Given this list of marker genes PRP4K, PHOX2B, MKX, SRF, FN1, CMC4, SULT4A1, DNAJC24, TBC1D4, SLC10A7, MYOCD, LINC02694, RAB33B, CADM2, C15orf40, GFRA1, ITGA1, NIPBL, BBX, LSM6, TRAM1L1, SLC6A15, TGFBR1, MVB12B, ZNF426, CD300E, MAPK1IP1L, PTPN2, ARL17A, NXPH1, RSPO3, LVRN, TMEM59, MRC1, PLEKHG7, SOX14, RGL1, GPR135, ARID1A, FZD10, TMEFF2, GNG12, SLC39A8, BRD8, STEAP2, NALF1, PIK3R3, A1CF, CAPRIN1, SUCNR1, PIK3CA, ATP8B3, USP2, PCDH10, ZNF706, TRAPPC3, ALCAM, LPP, MYCBP, PURA, UBE2H, IL17RE, PHLPP1, NAP1L1, PLXDC1, AGO1, SPTLC2, ARID4A, UFSP2, STAT1, BID, ACOT13, MKNK2, PAK2, SOX12, PRAMEF13, ME2, KLB, FOXJ3, MBNL1, TRRAP, PIK3C2G, METAP2, KHDRBS2, METTL8, SP100, GLCCI1, KCNK9, PRAMEF14, SAA2, PCDHB9, POGZ, ZNF660, CD36, SOX9 (SRY-box transcription factor 9), ABRACL, PDE12, BBS2, EIF2AK2, MTRFR, SLC22A17, C1QTNF7, CA3, GNL3, NLK (NCBI Gene Id 51701), ELP4, RAPGEF2, ZNF24, FGF12, SLC25A26, ITGBL1, MXI1, SDK1, BACH2, SH2D1A, CCDC178, BICD2, MAP3K2, BTG1, C1orf146, HEATR5A, ABCG8, MRPS5, COCH, POGK, CCDC125, ZNF268 (zinc finger protein 268), PSMA1, AMN1, TSPOAP1, NFIC, PHKA2, QKI, NRXN1, ONECUT2, C2orf69, ELMOD2, HECW2, ARHGAP36, ZNF652, DEDD, FBXL17, PRKAR2B, RAB27B, METTL9, IRF2BP2, NUDT15, NCALD, SLC35F6, TRMT9B, ADGRF5, MBD2, ANAPC15, GLRA2 (NCBI Gene Id 2742), SLC24A2, NRXN3, CDK14, RRN3, GCM1, PLK5, AIG1, STK3, CAMK1D, DNAJC6, HSD11B2, CD9, CAMK4, TGFB3, HPX, ERBIN, RFX7, TBXT, ABHD3, CCND1, ZIK1, POU4F1, LARP1, PRKG1 (NCBI Gene Id 5592), ZNF385C, HLTF, DNAJC13, SMARCA5, ZNF765, PARD3, ENPP4, FEM1C, NUDT19, ADAMTSL3, FOXA1, ERMN (NCBI Gene Id 57471), DPP10, TMEM243, TOB1 (transducer of ERBB2, 1), SPATA46, DUSP7, FGFR1OP2, APOD, KCNA1, SLK, ELAVL3, HIPK2, EMX2, OLFML2A, WWTR1, MBD6, BHMT2, KLF3, CYP26B1, CTCFL, ALDH1A1, NAIF1, DCK, SIK1, KDM2A, PTEN, TNRC6B, GPR161, AGTPBP1, RBM3, CLCN4, BCL6, KRBA2, TTC23L, SESN3, PRH2 (NCBI Gene Id 5555), RETNLB, MARCHF6, ZDHHC12, SOST, YY1, AGBL4, VTI1A, SCN3A, AHDC1, GARIN2, NHLH2, MAP7, TP63, NRCAM, MINK1, SPINK6, HAS2, ZNF704, CALHM5, LRP2BP, ANGPTL1, DDX18, TTC33 (tetratricopeptide repeat domain 33), PLA2R1, TRMT11, CREB1, PAX9, KCNC4, ASB15, PKD2, LYRM1, ENSG00000275993 (novel protein, similar to salt-inducible kinase 1 SIK1), EIF4G3, RAB2A, DISC1, ZC2HC1A, PAX8, TMEM47, ZNF521, SLC4A4, ACTR3, TUT7 (NCBI Gene Id 79670), ENSG00000215022, TRIP12, TAF5, NEUROD6, FNDC5, SERTAD2, MAFG, NIBAN1, CD8A, TMEM129, PCNX1, ERICH1, NTRK2, GCLM, ADTRP, TNRC6C, TIAL1, ATRX (NCBI Gene Id 6475), MIB1, LRRC4, THEMIS, MGST1, PRAMEF1, PEX5L, QRICH1, PICALM, CNOT7, RBKS, XYLB, ZNF480, GABRB1, FUBP3, LMTK3, TASOR2, ZNF611, TRUB1, GPR137C, TPRG1L, PHLDB2, GRM8, MRTFB (NCBI Gene Id 57496), CCDC152, IDI2, POU3F2 (NCBI Gene Id 5454), DCLRE1C, BICC1, MRPL34, IL24, CCDC102B, LSM14A, PRTG, EIF4H, ALPK3, MAP2 (NCBI Gene Id 4133), LEF1, PRUNE1, here is a description of the gene set: from publication Chen Y, Wang X (PMID 31504780) studied in species Homo sapiens Human Gene Set: MIR511_5P Genes predicted to be targets of miRBase v22 microRNA hsa-miR-511-5p in miRDB v6.0 with MirTarget v4 prediction scores > 80 (high confidence targets).